Given this list of marker genes Inpp5d, Cd59a, Ptprc, Arrb2, Serpinb9d, H2-M3, Havcr2, Serpinb9g, Tap2 (NCBI Gene Id 21355), Serpinb9, Serpinb9e, Serpinb9f, Klre1, Serpinb9h, Nectin2, Hsp90ab1, Serpinb9b, Mill1, Clec2d, Muc4 (mucin 4), Igf2, H2-T23, Serpinb9c, Cx3cr1, Ceacam1, Nectin4, Sh2d1b1, Ppp3cb, Gfer, Tap1, Crk, Klrb1b, Clec12b, Grb2, Tgfb1, Lgals9 (NCBI Gene Id 16859), Klrd1, Cd59b, Nckap1l, Il4 (interleukin 4), Il7r, Sh2d1b2, Il13, here is a description of the gene set: Any process that stops, prevents, or reduces the frequency, rate or extent of cell killing. species: Mus musculus Mouse Gene Set: GOBP_NEGATIVE_REGULATION_OF_CELL_KILLING